Given this list of marker genes DEFB4A, DEFB105A, GATA4, PRR23D1, ENSG00000282375, SUB1P1, RPS3AP31, FAM90A12, FAM66A, CLN8-AS1, LONRF1, MIR4659A, ENSG00000303064, ENSG00000306911, ENSG00000254340, ENPP7P1 (ectonucleotide pyrophosphatase/phosphodiesterase 7 pseudogene 1), FAM90A20, SNRPCP6, FAM90A24, FAM86B1, ARHGEF10, MIR5692A2, OR7E154P, DEFB108A, USP17L8, MIR598, TDH-AS1 (NCBI Gene Id 100129129), RN7SL318P, RNU6-526P, FAM85B, HSPD1P3, OR7E125P, FAM90A13, FAM66D, FAM90A11, MIR8055, MIR124-1HG, FAM90A17, ZNF705D, DEFB134, ENSG00000253887, FDFT1, FAM90A6P, KBTBD11-AS1, DEFB4B, USP17L4, PINX1-DT, ENSG00000299020, ENSG00000286985, DLGAP2, RNA5SP252, AGPAT5, RN7SL178P, MIR4659B, DEFB108D, RPS3AP30, DEFB103B, DEFB107B, OR4F21, KBTBD11-OT1, FAM90A23, OR7E10P, PPP1R3B, LINC02949, MIR124-1, VPS51P12, FAM90A19, ERICH1, OR7E158P, MIR597, MIR3926-1, RNU6-682P, DEFB104A, DEFB1, XKR5, CTSB (NCBI Gene Id 3896), FAM90A14, SNORA70, USP17L7, FAM167A, SNRPCP15, VPS51P19, TDRP, ALG1L11P, ZNF705B (zinc finger protein 705B), MIR548I3, FAM90A25P, DEFA6, DEFA9P, RPS3AP34, ANGPT2, DLGAP2-AS1, PRSS52P, XKR6, ENPP7P12, DEFB135, DEFA4, FAM66B, DEFB130B, HSPD1P2, LINC00208, SEPTIN14P8, RPL17P29, ENPP7P6, RNU6-1084P, RPL23AP96, DEFB105B, DEFB109B, ZNF596, DEFB136, RPL23AP53, SNRPCP17, FAM66E, FAM87A, RN7SL293P, SOX7, TDH, DEFA3, FAM90A22, PRR23D3P, FAM86B2, NEIL2, FAM86B3P, VPS51P9, OR7E161P, VPS51P14, RPL23AP54, LINC02950 (NCBI Gene Id 123466212), FAM90A21P, ENSG00000287747, RNU6-1151P, MIR7160, ENSG00000254007 (NCBI Gene Id 124902045), DEFA11P, DEFA1B, MIR596, OR7E96P, PRSS51, DEFA1, RPS3AP35, DEFB104B, PRSS55, ENSG00000299322, MIR4660, DEFA8P, KBTBD11, LINC00529, FAM90A9, SPAG11A, MIR3674, DEFB131C, ENSG00000269954, SPAG11B (NCBI Gene Id 51756), MCPH1-DT, FAM90A18, ZNF705CP, PRR23D2, GS1-24F4.2, RNA5SP254, DEFT1P2, RN7SKP159, DEFB131D, ENSG00000283674, DEFB130A, DEFB106A (defensin beta 106A), DEFB109A, RP1L1, MSRA, RNU6-729P, OR7E15P, MFHAS1, DEFB108E, FBXO25, VPS51P16, DEFA7P, ALG1L12P, USP17L3, C8orf74, LINC00681, ENSG00000304969, ENSG00000254237, ZNF705G, MCPH1, LINC03021, OR7E157P, RPS3AP33, ENSG00000253130, PPP1R3B-DT, DEFA5, PRAG1, FAM90A3, ERI1, TNKS, FAM90A5, ENSG00000254839, MYOM2, MSRA-DT, FAM90A7, FAM90A10, MIR4286, DEFB107A, USP17L2, DEFB106B, FAM90A4P, OR7E8P, LINC03022, ALG1L13P, CLN8, CLDN23, SOX7-AS1, CSMD1, USP17L1, MIR1322, RPL19P13, MIR3926-2 (microRNA 3926-2), RPL10P19, FAM90A8, RNA5SP251, ENSG00000275427, RNU7-55P, VPS51P15, FAM90A2P, BLK, DEFB109C, FAM167A-AS1, PAICSP4 (phosphoribosylaminoimidazole carboxylase, phosphoribosylaminoimidazole succinocarboxamide synthetase pseudogene 4, NCBI Gene Id 780813), MTMR9, FAM90A16, PINX1 (PIN2 (TERF1) interacting telomerase inhibitor 1), ENSG00000297321, DEFB131E, DEFT1P, SLC35G5, FAM90A15, ENSG00000287464, DEFB103A, RNA5SP253, MCPH1-AS1, DEFB109D, ENSG00000246477, DEFB108C, DEFA10P, VPS51P8, WBP1LP3, here is a description of the gene set: species: Homo sapiens Human Gene Set: chr8p23